Given this list of marker genes Spcs1, Oaz1, Oaz2, Sp1, Mid2, Eif3f, Rrp1b, Oaz3, Ccl5, Eif3a, Ccl3, Jun, Rsf1, Trim11, Eif2ak4, Ssb, Mcts1, Notch1, Zfp639, Eif3g, Pcbp2, Zfp36, Tarbp2, Paip1, Trim62 (tripartite motif-containing 62), Pou2f3, Eif2d, Dhx9, Ctdp1, Smarcb1, Mon1b, Ep300, Mdfic, Ccnt1, Cdk9, Eif3d, Trim27, Trim31, Eif3b, Trim21, Rest, Ubp1, Hdac1, Nucks1, Spcs3, Ifitm3, Gtf2b, Taf11, Snw1, Tardbp, Usf1, Map3k1, Smarca4, Atg12, Trim14, Shfl, Inpp5k, Ccnt2, Brd4 (NCBI Gene Id 57261), Denr, Hmga2, Hpn, Peg10, Csde1, Ptbp1, Chd1, Trim32, Sp100, Lef1, Eif3l (eukaryotic translation initiation factor 3, subunit L), Trim8, Pfn1, Hexim1, Atg5, Larp7, Trim13, Tfap4, Larp7-ps (NCBI Gene Id 68280), Ifitm7, here is a description of the gene set: studied in species Mus musculus A process by which a viral gene is converted into a mature gene product or products (proteins or RNA). This includes viral transcription, processing to produce a mature RNA product, and viral translation. Mouse Gene Set: GOBP_VIRAL_GENE_EXPRESSION